The following is a description of a gene set: studied in species Mus musculus Mouse Gene Set: GOBP_MITOTIC_METAPHASE_CHROMOSOME_ALIGNMENT A chromosome localization process whereby chromosomes are positioned in a specific order and orientation at the metaphase plate (spindle equator), during mitotic chromosome segregation. This alignment ensures that each daughter cell will receive the correct number of chromosomes during cell division., and this is the list of marker genes: Aurkb, Ska3, Chmp3, Chmp4b, Cdca8, Ankrd53, Vps4b, Kifc1, Ndc80, Cenpc1, Nup62, Nudc, Kat2b, Rab11a, Kpnb1, Ttk, Psrc1, Ska2, Becn1, Pibf1, Kat5, Kif14, Ska1, Eml4, Vps4a, Dctn2, Cdca5, Kifc5b (kinesin family member C5B), Eml3, Ccnb1 (cyclin B1), Chmp2a, Zw10, Pinx1, Chmp1b, Cul3, Champ1, Kif2c, Cenpe, Spdl1, Seh1l, Chmp5, Kif18a, Hnrnpu, Chmp1b2, Rrs1, Mis12, Kif22, Mad1l1, Birc5, Cdk1, Nuf2, Sirt1, Chmp1a, Cdt1, Cdc23, Chmp7, Snhg15, Mapre1 (NCBI Gene Id 99354), Chmp4c, Chmp6, Incenp, Chmp2b, Ccdc66, Ccnb1-ps